Given this list of marker genes PI4K2B, GIMAP4, LATS1, TREX1, JPH1, IL2RA, CHRDL1, DNAJC12, MAIP1, TNIP2, SQOR, ISM1-AS1, NCF1C, CASP9, RAD51, IQGAP2, SCML1, KLRK1, PDE4B, ALPK1 (NCBI Gene Id 80216), UBE2L6, CD59, GZMK, LRP11, BTLA (B and T lymphocyte associated), ITM2A, IFI27, GPR174, GIMAP1, UNC119, CHST11, LYSMD1, PSMB9, CRACR2A, EPSTI1, STAT1, IRF8, ETV6, CYB5A, TAFA4, RDX, GNL1, TGIF1, PELI1, FRMD6, PMS2P9, BASP1, LGMN, PLEKHG1, LMO4, OXNAD1, ARID5B, LTA, GBP4, SUSD6 (sushi domain containing 6), LIX1, REXO2, MAST4, SMAD9, FIRRM, SLC22A4, SYNE3, GRK3, INTS8, AHNAK, CXCL9, GBP5, TOPBP1, GBP1, BCORP1, DTX3L, HIVEP2 (NCBI Gene Id 3097), GPR155, LINC00310 (NCBI Gene Id 114036), CD200, GCH1, SUSD3 (NCBI Gene Id 203328), SIRT1, STX11, LAMP3, PGAP1, SELL, GNPDA1, DUSP4, PPP4R1L, SLAMF1, GIMAP7, WIPF1, MAFF, PITPNC1, KMT2A, TMEM243, ZFAND4, CASP3, PTGER4, TSR1, C11orf40, PAG1, ATXN7L1, TAP1, EBI3, PELI2, NXPE3, IFIH1, LYST, RGCC, PIK3CB, IFIT5 (NCBI Gene Id 24138), ZG16B, CD226, TRAT1, CD58, SNX25, BCL2L14, CDH3, ARHGAP21, ANXA2, CD38, SIAH3, C3orf52, PSMB10, LINC00326, KSR1, PARP14, GINS2, SPRYD3, CLEC2B, TIFA, ISG15, STX3, PSME4, SNRPC, TRPC3, PARP11, SMAD7, SP140, SCAMP3, RHOU, RFC4 (NCBI Gene Id 5984), NFE2L3, LGALSL, LGALS12, IFI35, PRG3, GIMAP8, RSPO3 (NCBI Gene Id 90095), NLRP8, KAT2B, VOPP1, ARHGAP15, RRAS2, LYSMD2, RIPOR1, TNFSF10, KCNE4, SLC44A1, PRKCH, RAPGEF2, PCTP, XRN1, RNF169, CRTAP, TLR1, WNT9B, TRIM22, CD274, MLLT3, TNFSF13B, ZC3H7B, MTMR1, GSTO1, BIRC3, NEXN, CYFIP1, PARP9, LACC1, WDR82, DUSP16, MYH16, CACUL1, MIR155HG, FANCI, GADD45G, DPP4, CLUHP3, CCNE1, SOCS2, CRISPLD1, NFE4, NETO2, ATP1B1, TRIM6, SNX9, SAMD9L, JAGN1 (NCBI Gene Id 84522), here is a description of the gene set: from publication Elo LL, Järvenpää H, Tuomela S, Raghav S, Ahlfors H, Laurila K, Gupta B, Lund RJ, Tahvanainen J, Hawkins RD, Oresic M, Lähdesmäki H, Rasool O, Rao KV, Aittokallio T, Lahesmaa R (PMID 20620947) studied in species Homo sapiens The aim of this dataset was to study in detail the transcription kinetics initiated by cytokine IL-4 in early differentiation of Th2 cells. Genes down-regulated in comparison of CD4 T cells treated with IL4 and anti-IL12 at 72 h versus the untreated cells at 72 h. Human Gene Set: GSE17974_IL4_AND_ANTI_IL12_VS_UNTREATED_72H_ACT_CD4_TCELL_DN